The following is a description of a gene set: studied in species Mus musculus Any process that activates or increases the frequency, rate or extent of microglial cell migration. Mouse Gene Set: GOBP_POSITIVE_REGULATION_OF_MICROGLIAL_CELL_MIGRATION, and this is the list of marker genes: Cx3cl1, Trem2, Cx3cr1, Csf1, P2rx4, P2ry12